Given this list of marker genes DLG4, CACNG7, BIN1, NFIB, DAB2IP, CACNG2, SLC17A7, LRRC4B, here is a description of the gene set: Human Gene Set: GOCC_CEREBELLAR_MOSSY_FIBER species: Homo sapiens An axon arising from cerebellar projecting cells in the cochlea, vestibular nuclei, spinal cord, reticular formation, cerebellar nuclei and basilar pontine nuclei. Mossy fibers enter through all three cerebellar peduncles and send collaterals to the deep cerebellar nuclei, then branch in the white matter and terminate in the granule cell layer. Through this branching, a given mossy fiber can innervate several folia. Mossy fibers synapse on granule cells. The synaptic contacts are made at enlargements along the length of the mossy fiber called mossy fiber rosettes. The enlargements of the rosettes give the axons a mossy-looking appearance in Golgi stained preparations.